Given this list of marker genes Clu, Fcgr2b (NCBI Gene Id 98391), Ccr2, Ccl2, Pla2g5, Cfh, here is a description of the gene set: A process directed at removing immune complexes from the body. Immune complexes are clusters of antibodies bound to antigen, to which complement may also be fixed, and which may precipitate or remain in solution. studied in species Mus musculus Mouse Gene Set: GOBP_IMMUNE_COMPLEX_CLEARANCE